Given this list of marker genes FOXO1 (forkhead box O1), OTUD7B, H2AZ2, UBL3, WBP4, GATA6, LASP1, IRS4, ADGRL2, ATF7IP, PFDN6, IKZF2, KCNJ15, ORC1, PMCH, AKT1S1, HCAR3, LINC00173, CREBRF, GRB7, YTHDF3, PTPRD, DDIT4, NIM1K, KMT2E (lysine methyltransferase 2E (inactive)), THRA, EPHB1, CDKN1C, ABLIM3, BMI1 (NCBI Gene Id 648), PHACTR3, PTCHD1, ELOVL6, SYT16, SEMA6D, ZEB2 (zinc finger E-box binding homeobox 2), SLC38A2, KLHDC2, FGF12, RUNX1, WDR46, PREX2, NPVF, PHF21A, HBP1, POU3F2, KCNJ5, ITPR3, CCDC89, GFRA1, SH3BP5, ATXN7L1, LINS1, PAPPA, TSPYL2, DUSP1, LRRC1, NMNAT2, OPA3, CNNM3, CCN1, CSRNP3, HOXA3, KLHL40, HHEX, MITF, ELOA2, FAM110A, STOML3, CLDN2, SREK1, HTN1, DLX1, ZNF366, OSR1, ASXL1, TMEM88, LMO3, USP3, TPD52L3, POU3F4, EML1, NDRG1, FOXN3, CRH, SZT2, MED8, TRIM8, UBE2H, IL1RAPL1, EMP1, KDM3A, PITX2, H2AX, OLIG3, CBFA2T2, GPRC5C, SDK2, PLXDC2, NSD3, LCP2 (NCBI Gene Id 3937), NFYA, MXRA8, NSG2, DEDD, NFIB, SNCAIP, CREM, SLC25A28, CHD1, PDCD4, CHCHD7 (coiled-coil-helix-coiled-coil-helix domain containing 7), HIPK1, TDRD5, EPHB3, NFIX (nuclear factor I X), ESRRG, ARFGEF1, NNT, ADGRF1, AP4M1, HCAR2, PPP1CB, NRN1L, SESN3, H3-3B (NCBI Gene Id 3021), PLCB2 (NCBI Gene Id 5330), SLC10A7, CADPS, ASB7, KDM6A, INHBA, SMAD1, SIAH3 (NCBI Gene Id 283514), TSC1, FGF9, SCUBE3, DMD, SPAG9, FSTL1, PURA, SLC26A7, ARK2N, OARD1, ZNF385B, IL25, ETV1, KRT85, GPR174, GTF2B, PALM, IER5L, RASGEF1B, BMF, ZBTB22, HOXC4 (NCBI Gene Id 50712), PRDM1, FAM53B, SH3GL3, ZBTB16, BCL11B, CSAD, WFIKKN2, TBCC, HSPB2, SLC26A2, WBP1L, APOA2, EZH1, ARID4A, CSNK1G3, TAS2R39, SLITRK6, IGSF1, ZNF654, NF1, LAG3, ELAVL2, LMO4, NKX2-2, SALL3, CCND1, TBC1D17, HMCN1, ETV5, C1orf43, FOXP2, WIPI2, CXXC5, SSBP3, TBX4, TAFAZZIN, AXIN2, SLC25A34, PLAG1, NRG1, C2orf69, ZMAT4, GPR18, SEMA4G, EFEMP1, RBFOX1, BDNF, RTL9, ZFYVE1, PTGR3, BUB3, HOXB8, MCM7, CCNG2, SCML1, SCRN3, LHX5, KCNN1, NR2C2, HOXA11, DDX17, BIN1, PRPF38A, GPR63, PTCHD4, SLITRK5, HOXB4, ZBTB18, HESX1, ANKRD28, FGF14, SOX2, CRB1, C12orf50, PROX1 (prospero homeobox 1), CIMAP1C, CRTC2, EXT1, SYT6, MGLL, NTRK3, FST, KLF12, IMPDH2, TRIM63, LUC7L3, GRIK3, EIF4EBP2, NR4A2, LHX1, C1QTNF3, DTNA, here is a description of the gene set: studied in species Homo sapiens Human Gene Set: FOXO1_01 Genes having at least one occurrence of the motif NRWAAACAAN in the regions spanning 4 kb centered on their transcription starting sites. This matches the FOXO1A transcription factor binding site V$FOXO1_01 (v7.4 TRANSFAC).